Given this list of marker genes Bptf, Agfg2, Nexmif, Met, Tet1, Dnaaf9, Zmynd11, Adgrf5, Ralgds, Adap2 (NCBI Gene Id 216991), Prkar1a, Ntrk2, Sdc4, Mosmo, Kalrn, Gpr137c, Vps39, Ammecr1l, Spag9, Def8, Necap2, Zfp710, Rab3b, Epha4, Tex264, Klhl23, Fgf1, Pou2f3, Lmna, Ret, Atad2b, Rbfox1, Zbtb47, Cpq (carboxypeptidase Q), Rap2c, Rnf157, Nup153, Spryd7, Kcmf1, Onecut2, Ptpn1, Camta2, Irf2, St3gal2, Nceh1, Plppr4, Smim14, Clasp2, Bbc3, Hoxb9, here is a description of the gene set: Genes predicted to be targets of miRBase v22 microRNA mmu_miR_7668_3p in miRDB v6.0 with MirTarget v4 prediction scores > 80 (high confidence targets). Mouse Gene Set: MIR_7668_3P from publication Chen Y, Wang X (PMID 31504780) species: Mus musculus